Given this list of marker genes Atp8a2, Kcnn4, Plscr1l1, Mfsd2a, Triap1, Slc4a1, Tmem41b (transmembrane protein 41B), Ano6, Atp8b2, Abcg1, Atp8b1, Ano3, Atg9b, Xkr7 (X-linked Kx blood group related 7), Ano4, Atp8b4 (ATPase, class I, type 8B, member 4), Abcb4, Abca12, Plscr5, Tmem30b, Serinc5, Xkr4, Xkr8, Vmp1, Vdac2, Plscr1, Abca1, Clptm1l, Atp11b, Abca4, Atg9a, Atp10a, Tmem30c, Slc66a2, Gba2, Atp9a (NCBI Gene Id 11981), Abcb1b, Abca2, Tlcd2, Ano7, P2rx7, Atp11c, Ano9, Tlcd1, Plscr3, Atp8b5, Fasl, Xrcc4, Xkr9, Serinc3, Plscr2, Plscr4, Atp10d (ATPase, class V, type 10D), Abcc1, Atp8b3, Atp8a1, Atp11a, Trpc5, Xkr6, Abcb1a, Abca7, Rft1, Abca3, Prelid1, Atp9b, Serinc2, Atp10b, Tmem30a, Arv1, here is a description of the gene set: Mouse Gene Set: GOBP_REGULATION_OF_MEMBRANE_LIPID_DISTRIBUTION Any process that modulates the proportions or spatial arrangement of lipids in a cellular membrane. studied in species Mus musculus